Given this list of marker genes CAMSAP3, NECTIN2, PLEKHA7, KIFC3, VCL, JUP, SORBS1, CTNNA1, here is a description of the gene set: A cell-cell adherens junction which forms a continuous belt near the apex of epithelial cells. Human Gene Set: GOCC_ZONULA_ADHERENS species: Homo sapiens